The following is a description of a gene set: Human Gene Set: AIZARANI_LIVER_C13_LSECS_2 species: Homo sapiens from publication Aizarani N, Saviano A, Sagar, Mailly L, Durand S, Herman JS, Pessaux P, Baumert TF, Grün D (PMID 31292543), and this is the list of marker genes: IL33, MAN1C1, NFIB, GATA4, TPM4, ERG, CLEC3B, ADM, TMEM255B, NXPE3, IL4R, ATP13A3, F2RL3, FLT1 (NCBI Gene Id 2321), TLR4, TIMP1, LRATD1, PRCP, ANPEP, SLC7A8, CUL4B, HES1, S100A16, TSPAN18, PPFIBP1, CLDN5 (claudin 5), CCL15-CCL14, GARRE1, MRC1, SHC2, WSB1, COL4A1, TEK, CAVIN1, WARS1, FXYD6, CCL14, MRO, LIMS2, ST6GALNAC3, RDX, AKAP12, CLEC1B, RNF115 (NCBI Gene Id 27246), CNN3, EHD3, IFI27, CDH5, PDLIM1, IFITM10, ELK3, MID1, ZNF765, IGFBP7, TAMALIN, FILIP1, DLL1, TMEM44, EDN1, DENND4C, SLC16A1-AS1, SELENON, ZNF160, FAM107A, APP, SHE, GNG11, EMCN, EPOR, PIM3, COL4A2, CRHBP, STAB1, PECAM1, PXDN, TGFBR3, CTSD, KLF4, NR2F2, CLEC4M, ALPL, ITPRIP, MEIS2, DUSP5, SHANK3, TM4SF1, COL6A2, FCGRT, AFF1, ARAP3, SLC27A3, ID1, GBP4, ZNF117, SGSM1, SNTB2 (NCBI Gene Id 6645), SMTN, NID1, SLCO2A1, A2M, CD93, TIMP3, TNS2, ADGRF5, GIMAP8, CD4, NPR1, TMEM256-PLSCR3, C11orf96, ENG, PGM5, CXCL16, NPL, EPHB4, MYCT1, TFPI, FEZ1, HYAL2, RELN, CSRNP1, ZCCHC24, SEC14L1, IL6ST, ACP5, FCN3, HECW2, MARCKSL1, PCDH17, MXD4, GAS2L1, SH2D3C, SERPINH1, F2R, BAIAP2, SASH1, LGMN, TP53I11, FLNB, KDR, FGFR1, TCN2, SEMA6A, TIMP2, NPY1R, FLT4, PHACTR2, GJA4, NUAK1, ACTN1, MS4A6A, APLNR, MARCKS, LPAR6, FAM167B, C5AR2, ADD3 (NCBI Gene Id 121), NTS, APOL1, PREX2, KLF7, ID3, RASIP1, CALU, NRP1, NR2F1, IFI44L, ADAMTS4, HDAC7, ASAP1, IFITM3, SGK1, TMEM37, TIE1, FZD4, TGFBR2, ADGRL4, SPRY4, FSCN1, EFNB2, TRIOBP, EDNRB, PLTP (phospholipid transfer protein), NPDC1, LYVE1, NISCH, PALM, TMCC3, TSPAN14, RNASE1, PTPRB, MYO10, C1QTNF1, STAB2, EGFL7 (NCBI Gene Id 51162), MAP3K6, MMRN2, MAF, TCIM, EFNB1, ZNF451, TUG1, IGFBP4, LIFR, CDC42EP4, PDK4, TSPAN7, PDE2A, NEDD9, TM4SF18, DAB2, RASAL2, EPAS1, TACC1, EXOC3L2, BST2, CFP, PCAT19, TBC1D4, SMAD6, HEG1, SDCBP, SLCO4A1, FCN2, TCF4, NOTCH4 (notch receptor 4), SPARC, RAMP3, OIT3, NTN4, DLC1, BTNL9, LAMB2, HIPK2, ECE1, MYO1C, ANKS1A, PLXND1 (plexin D1), GALNT15, NOVA2, MEG3, CD36, LDB2, HLA-E, RAPGEF5, ROBO4, NRP2, GPR182, CALCRL, TCF7L1, NHERF2, FCGR2B, CLEC14A, ESAM, PLAC8, DAAM1, USP13, PRSS23, INSR, PLPP3, NOS3, APOLD1, NOSTRIN, DNASE1L3, TMEM204, CAVIN2, RPGR, CD14, KLF2, CTSL, LIMCH1, LAPTM4B, IL1R1, BSDC1, CD59, F8, TINAGL1, ARHGEF7, TFPI2, PDE7B (phosphodiesterase 7B), CPNE2, RAMP2, TGM2, CLEC4G